The following is a description of a gene set: species: Mus musculus Calmodulin-dependent catalysis of the reactions: ATP + a protein serine = ADP + protein serine phosphate; and ATP + a protein threonine = ADP + protein threonine phosphate. This activity require the presence of calcium-bound calmodulin. Mouse Gene Set: GOMF_CALCIUM_CALMODULIN_DEPENDENT_PROTEIN_KINASE_ACTIVITY, and this is the list of marker genes: Ptk2b, Mapkapk5, Camk1, Mapkapk2, Camk2b, Prkag2 (protein kinase, AMP-activated, gamma 2 non-catalytic subunit), Camkk2, Camk2d, Camk4, Elp4, Phkg1, Camk1d, Camk1g, Mylk3, Itpka, Camkv, Dapk1, Mknk1, Mapkapk3 (NCBI Gene Id 235596), Camk2a, Pnck, Camk2g, Phkg2, Mknk2, Eef2k, Elp3, Camkk1